Given this list of marker genes MX1, CEP85, LYRM1, XYLT2, CAMSAP1, DTYMK, FLRT2, COPZ2, FUT8, EIF2S2, TUBD1, PGM1, TOP1MT, FGF11, FCSK, DNASE1L3, TADA2A, SUMO1, ELOC, EEA1, HARS2 (NCBI Gene Id 23438, histidyl-tRNA synthetase 2, mitochondrial), PGRMC2, HOXD13, ARHGEF15, ADH1A, MAGED1, GAS2, RNF220, ADARB1, ITPK1, VWA3A, NFX1, LMNB2, CTTN, TMEM42, ADORA2B, TRMT1, NUFIP1, CDC20, PRCC, ATRNL1, SNX27, TARBP1, PPM1F, JPH1, ZFPL1, ZC3H8, P4HA2, MS4A3, NELFCD, NECTIN2, MBLAC2, PPP1R7, TBX5, PTPA, PDXK, SPINK8, TSPAN15, SH3TC1, LRFN3, GTF2A1L, TRIP6, TMEM43, TESC, UNC13B, USP10, WDR4, CD200R1L, MPZL3, CCDC112 (coiled-coil domain containing 112), CCDC150, PRMT6, COL8A2, PCED1A (NCBI Gene Id 64773), HDAC5, MAS1, LOX, COL25A1, KRT77, HDC, ADAM3A, ITPRIPL2, LSM5, LMO3, BCAM, HDAC11, CES1, TLCD1, CYB5RL, WNT3, OOSP1, LMAN1, POMT2, PLOD3, RPF2, KIR3DL1, CPQ, WSB2, MTERF2, PPAN, HOPX, RRAGA, COX7A1 (cytochrome c oxidase subunit 7A1), FBXO7, TRMT10C, MIR206, CKLF, IL21R, SLC4A4, SDHC, HMGXB3, CCL4, GPM6A, CENPQ, PNP, SATL1, FCRL5, AACS, RAPGEFL1, PLA2G4C, LAMTOR2, QRSL1, CWH43, ICA1, ST3GAL5, NR2F2, SEMA4C, ROS1, RRAGB, MEGF10, ZFP30, FIGNL2, ZFP69 (ZFP69 zinc finger protein), KCNJ2, NOL10, GOLGA2, TMEM177, here is a description of the gene set: Human Gene Set: GSE34217_MIR17_92_OVEREXPRESS_VS_WT_ACT_CD8_TCELL_DN Genes down-regulated in act CD8 T cells: over-expressing MIR17HG versus activated control. species: Homo sapiens During acute viral infections, effector CD8+ T cells differentiate into memory precursors or short-lived terminal effectors. miR-17-92a over-expression skews CD8+ effector cells to the terminal differentiation. We used microarray to identify the genes that are differentially expressed caused by miR-17-92a over-expression. from publication Wu T, Wieland A, Araki K, Davis CW, Ye L, Hale JS, Ahmed R (PMID 22665768)